Given this list of marker genes SMARCD2 (NCBI Gene Id 6603), ZFYVE9, FAT3, ZFYVE26, ABRAXAS2, TNRC6C, PXK, HEG1, CENPO, FRZB, SPTY2D1, ACSL1, GTF2H1, ST8SIA5, LGALSL, TET3, AKAP1, GJA1, PURG, MAPK1, HECA, RALGPS2, CNOT7 (CCR4-NOT transcription complex subunit 7), SPOCK1, ZNF862, SPEN, CAMSAP2, TMOD1, ACVR1, BAG5, ITPRIPL2, INSIG1, BPTF, DENND10, APCDD1, MMGT1, SKIDA1, LDLRAD4, SPATA2, EIF4E2, AGO4, AKIRIN2, RNF145, PPP6R2, BTBD7, MBNL1, DDX6, TSC1, NCKAP5, MCTP1, RAPGEF4, ERCC4, CALM2, PRUNE2, MDFIC, PHF12 (PHD finger protein 12), FSTL5, FMC1, KIF13A, FYN, CSMD1, MTCL1, IL15, BTG1 (BTG anti-proliferation factor 1), RAD51B, CDS1, UBB, SAR1B, CNOT4, RASD1, NPAT, NABP1, PIP4P2, SERBP1, SFMBT1, DLL1, WDR20, NPNT, FASTK, LCORL, CCDC126, CLCN3, TRPC3, MTMR10, TGFBR2, SOCS5, DNAJC16, RPS6KA5, HECW2, BAHD1, EGLN3, DYNC1LI2, ANKIB1, ARAP2, SNX31, SNIP1, ROBO2 (roundabout guidance receptor 2), ZNF800, FOXF2, FOSL1, CCNY, PPFIA2, CBY1, LY75, ULK2, NHLH2, WEE1, DSEL, POU4F1, MET, LONRF3, PHACTR2, STON2, ARHGAP12 (Rho GTPase activating protein 12), CBX6, HIVEP2, ZBTB20, LDAF1, CAPRIN2, PGM2L1, JARID2, BRWD3, PHF20, SIX4, TOGARAM1, TMEM50B, TBL1XR1, AR, LMLN, USP13, CGGBP1, DAAM1 (dishevelled associated activator of morphogenesis 1), DLG5, WDR47, ABHD3, OTUD3, RAB5A, CD2AP, BRWD1, MSMO1, ZBTB4, SHANK2, GAREM1, THSD7A, LDLR, PAK6, ARL6IP1, WDFY3 (WD repeat and FYVE domain containing 3), CLTC, ZNF594, DOCK3 (NCBI Gene Id 1795), EPS15, ATP6V1B2, NEUROG1, LRP6, PPARG, AKAP11, EREG, LRIG1, MEMO1, ERP44, UBA3, CD69, UBE3B, MIGA2, RBBP8, WDR33, SALL3, SULF1, ZNF217 (zinc finger protein 217), CBFB, CEP170, EOGT (NCBI Gene Id 79580), RAP2C, CCDC6, PCNX1, ENPP5 (ectonucleotide pyrophosphatase/phosphodiesterase family member 5), BTBD3, FIBIN, FBXO28, JADE1, IL1RAP (interleukin 1 receptor accessory protein), SNX2, INO80, RACGAP1, THOP1, NACC2, PTPN4, RRAGD, CFL2, R3HDM1, APPL1, ACSL4, DGKE, SZRD1, MAP3K20, CPEB3 (cytoplasmic polyadenylation element binding protein 3), DSG1, ZBTB18, USP8, ACBD3, RNF216, PDZD11, AAK1, DENND4C, ARHGEF26, KLF7, USP33, CYP2U1, MAP3K12, DNAL1, TEX2, ESR1, BTAF1 (NCBI Gene Id 9044), NPEPL1, STIM2 (NCBI Gene Id 57620), HCFC2, PIKFYVE, PIK3C2A, DCBLD2, STX6, DYNLL2, WNK1, ADCY1, TES, SPHK2 (NCBI Gene Id 56848), MIER1, RO60, ZMAT3, PAN3, LPGAT1, SNX5, FERMT2, ZEB2 (NCBI Gene Id 9839), SLMAP, ATP12A (ATPase H+/K+ transporting non-gastric alpha2 subunit), ACBD5, RUNX3, EMX2, CPEB1, AGO1, RAB12, NSD3, MAF, ABCB7, PPP1R15B, NALF1, G3BP2, ADAM12, EPC2, NECTIN3, DCUN1D3, G0S2, LRP12, PLCB1, TGFBR1, ZNF107, ERBIN, MBNL3, PSAP, PHAF1, BMPR2, UBXN2B, AGFG1, MIGA1, EDN1, ING2, MFSD6, KBTBD8, BTF3L4, VPS13D, KRTAP26-1, SECISBP2L, BMP3, SMOC1, NRBF2, RNF38, TFCP2L1, PLAA (NCBI Gene Id 9373), CHST1, UBE2D2, NFIA, HS3ST5, POU3F2, TANC2, DLC1, SOS2, FMR1, JMY, DIAPH3 (diaphanous related formin 3), C2orf15, FSD1L, KCNA4, HOXA3, PEX5L, LRP8, ABCC5, SAMTOR, CNOT6, PDIK1L, TENT2, SYBU, NFIB, EBF3, VPS37A, MECP2, FZD6, TLCD3A, CHD5, IRF1, TMEM250, LSMEM1, PRKD3, ARHGAP1, SLAIN1, HOXD1, UBE2W, MBD2, PTP4A1, SLC6A6, TRIM2, DCAF8, KIAA1191, LRP2, YTHDF2, TSHZ1, HPRT1, MDM4, CASD1, USP28, CRACD, RTN1, PMEPA1, CYSLTR1, MLLT6, SAMD8, SYT6, KDM2A, BHLHE41, RAI2, SLC2A4RG, ITPR1, PSD, ZNF609, VGLL4, HSPA8, CUL3, ATG14, PTPRG, BLCAP, SBF2, RFX7, FBXO48, SH3D19, TAFA1, MB21D2, OSBPL6, SEL1L3, DICER1, ST18, SERINC3, GADD45A, SLC44A1, SPART, ELK3, ARHGEF4, RBM25, PIGA, SCUBE3, CDK19, CLCN5, LRRTM2, SRSF2, CBLB, ITGB8, ATG16L1, MID1IP1, POP7, ARHGAP21, FRMD6, VCF1 (VCP nuclear cofactor family member 1), SBNO1, CLIP1, MACIR, PIK3CB, PHF14, RTCA, ASXL2, IGF1, DPYSL2, MPHOSPH9, IMPDH1, PRKAA1, KMT2C, MYBL1, FUT9, here is a description of the gene set: Human Gene Set: MIR301B_3P species: Homo sapiens Genes predicted to be targets of miRBase v22 microRNA hsa-miR-301b-3p in miRDB v6.0 with MirTarget v4 prediction scores > 80 (high confidence targets). from publication Chen Y, Wang X (PMID 31504780)